The following is a description of a gene set: species: Homo sapiens Any process that stops, prevents or reduces the frequency, rate or extent of protein targeting to mitochondrion. Human Gene Set: GOBP_NEGATIVE_REGULATION_OF_PROTEIN_TARGETING_TO_MITOCHONDRION, and this is the list of marker genes: SIAH3, BAG4, C11orf65, BAG3, LRRK2, LMAN1